The following is a description of a gene set: Duplication or mutation-activated FLT3 to RAS-ERK signaling pathway. Pathway ID: N00004. Pathway type: Variant. Pathway class: nt06275 Acute myeloid leukemia. species: Homo sapiens Human Gene Set: KEGG_MEDICUS_VARIANT_DUPLICATION_OR_MUTATION_ACTIVATED_FLT3_TO_RAS_ERK_SIGNALING_PATHWAY Pathway Definition from KEGG: FLT3* -> GRB2 -> SOS -> RAS -> RAF -> MEK -> ERK, and this is the list of marker genes: MAPK1, GRB2, NRAS, KRAS, SOS1, HRAS, ARAF, SOS2, BRAF, RAF1, MAP2K2, MAPK3, FLT3, MAP2K1